The following is a description of a gene set: The process whose specific outcome is the progression of the central nervous system over time, from its formation to the mature structure. The central nervous system is the core nervous system that serves an integrating and coordinating function. In vertebrates it consists of the brain and spinal cord. In those invertebrates with a central nervous system it typically consists of a brain, cerebral ganglia and a nerve cord. species: Mus musculus Mouse Gene Set: GOBP_CENTRAL_NERVOUS_SYSTEM_DEVELOPMENT, and this is the list of marker genes: Slc4a7, Cldn3, Rnf7, Cckar, Tbc1d23, Lpar1 (lysophosphatidic acid receptor 1), Fmr1, Uqcrq, Ints15, Sema5a, Wdr62, Gfap, Grid2, Meis3 (NCBI Gene Id 17537), Ptf1a, Cxcl12, Aatk, Olig2, Arhgap32, Thoc6, Fezf1 (NCBI Gene Id 73191), Sez6, Cdh2, Mtf1, Mios, Pex5, Fgfr3, Hprt1, Top2b, Apod (NCBI Gene Id 11815), Ndel1, Cdon, Ryk, Faim2, Grn, Tgfb1, Opalin, Ckap5, Hap1, Fgf10, Mir124a-2, Fut1, Bbs2, Sox6, Agbl4, Wdr47, Ntrk2, Sox3, Reck, Kndc1, Rtn2, Tppp, Norad, Ttc21b, Dll1, Zbtb18 (zinc finger and BTB domain containing 18), Epha4, Bcl6, Hspg2, mt-Nd4, Nf1, Brsk1, Arl13b, Ugp2, Comt, S100a9, Shh, Sall3, Ttc8, Slc1a2, Qars1, Cdk5r2, Mtpn, Nrcam, Gabrb3, Spag6l, Pax4, Aspa, Vps4b, Hmx3, C2cd3, Crtac1, Fat3, Sphk1, Tubb2b, Drd1 (dopamine receptor D1), Slc6a17, Zswim6, Kcna2, Nr2c2, Lep (NCBI Gene Id 16846), Tlr2, Glud1, Runx1, Foxn4, Celsr2, Dmrt3, Ssbp3, Gak, Aldh3a2, Nsun5, Abl1, Nrros, Flvcr2, B3gnt5, Srd5a2, Rab23, Nfasc, Eef1ece2, Irs2, B2m, Atf2, Gsx2, Rac1, Dclk2, Sct, Plxna4, Enpp2, Ptprz1 (NCBI Gene Id 433999), Rbbp4, Noto, Gpx4, Fa2h, Met, Eed, Dubr, Id4, Pcm1, Dock7, Slc8a3, Pfdn1, Spg11, Csnk2a1, Vim, Ldb1, Bloc1s6, Atp2b4, Actl6a, Slc6a3, Zmiz1, Mafb, Kif14, Cers1 (ceramide synthase 1), Vcan, Hes5, Ifng, mt-Co1, Cx3cr1, Sox9, Gbx2, Bmpr1b (bone morphogenetic protein receptor, type 1B), Mecp2, Rhoa, Pou3f3, Brsk2 (NCBI Gene Id 75770), Anapc7, Zic2, Scn1b (NCBI Gene Id 20266), Pax7, Nav2, Skor2, Zfp488, Celf1, Dbi, Atp1a3, Cntn1, Dhx30, Nkx2-6, Wasf3, Cited1, Dag1, Efna1, Lrp6, Tuba1a, C1qa (NCBI Gene Id 12259), Hnrnpk, Fbxo45, Hnrnpd, Fez1, Klhl1, Gstp1, Rogdi, Rtn4, Mapk8ip3, Draxin, Sez6l, Mecom, Gcm1, Dnaaf3, Glis2, Kdm7a, Whrn (whirlin), Dll4, Ercc2, Foxc1, Agt (NCBI Gene Id 11606), Csnk1d (casein kinase 1, delta), Dab1, Map2k1, Mir376a, Svbp, Vps13b, Trpv1, Lypd6, Taok1, Hesx1, Btbd3, Ptprj, Macroh2a2, Dscaml1, Fxr1, Prkdc, Brinp1, Ptk2, Zeb1, Sox5 (SRY (sex determining region Y)-box 5), Bsx, Myo16, Prkg1, Rab18, Fyn, Lhx1os, Lhx2, Hdac11, Hoxa1, Epha2, Fgfr2, Rpgrip1l, Hif1a, Dicer1, Sstr3, Casz1, Atp2b2, Fktn, Zhx2, Psen2, Bpgm, Ngfr, Tbx20, Mir124a-1, Kif1a, Crkl, Scrib, Epha7, Vit, Smarcc2, Mapk3, Xrn2, Trem2, Wnt1, Casp3, Ttpa, Pbx3, Ntf3 (neurotrophin 3), Sox10, Napa, H2aj, Tacc1, Frs2, Rere, Atg16l1, Rrm1, Tyrobp, Grhl2, Nr3c1, Meis1, Hdac2, Gpr17, Rheb, Efhc1, Pantr2, Sema6b, Dcc, Stxbp3, Smarca4, En1, Bcan, Inhbb, Pgap1, Ncor1, Wls, Kirrel3, Ghrhr, Cxcr2, Emx2, Th, Plpp3, Psap, Ecrg4, Slc7a11, Tubb2a, Mdk, Gata2, Egfr, Tnfrsf1b, Pex13, Zic5, Sptbn4, Atrx, Foxo3 (forkhead box O3), Cep120, Cdk5r1, Cfap43, Nrp2, Ndp, Cplane1 (ciliogenesis and planar polarity effector 1), Stat3, Gap43, Atp6ap2, Socs7, Neurog2, Gba1 (NCBI Gene Id 14466), Crh, Tacc3, Uchl5, Sirt2, Mapk1, Dbx1, Sox13, Stil, Mag, Abcb1b, Smg9, Kcna1, Pitx2, Ldlr, Itgb1, Nfix, Mib1, Ighmbp2, Mir9-2 (NCBI Gene Id 723967), Adarb1, Atm, Mas1, Exoc4, Amigo2, Spef2, Mettl14, Plcb1, Atoh1, Immp2l (IMP2 inner mitochondrial membrane peptidase-like (S. cerevisiae)), Ntrk3, Drp2, Erbb2, Hoxb3, Bbs1, Ext1, B3glct, Sox21, Wdr1, Stk4, Cul5, Ptn, Arhgap35, Gsk3b, Zeb2, Cdk5, Atp1b2, Prkca, Med12, Lhx8, Psen1 (NCBI Gene Id 19164), Lsr, Kras, Fzd3, Phox2a, Pou4f1, Acan, Fgf2, Cacna1a, Zfp335, Mtor, Neurog3, Aplp2, Mir20a, Abat, Psmg1, Matcap1, Cln8, Kcnq2, Hsd17b7, Pomt2, Enpp1, Gmppa, Cbs, Git1, Ulk1, Gsn, Aars1, Trp73, Tctn1, Gbx1, Hoxb8, Dkk1, Cntn4, Slc6a4, Trp53, Plxnb2, Drd3, Dlx2, Pou4f2, Fxr2, Coro1c, Dhx37, Sun1, Mir18, Kcne1, Vax1, Gdpd5, Scyl3, Mir200c, Tpp1, Pitx1, Akna, Avpr1a, Sstr1, Mir200b, C5ar1, Dner, Nr1d1, Rtn4r, Pou3f4, Ophn1, Pkd2, Il6st, Aim2, Gli3, S100a8, Mkks, Sphk2, Kif3a, Gdnf, Foxp1, Six3, Dctn1, Anxa3, Rtn4rl2, Tbx3, Foxg1, Shroom4, Pafah1b1, Robo2, Dmd, Jhy, S1pr1, Fzd4, Atp7a, Bmp4, Slc2a1, Pbx4, Odad2, Zpr1, Nrxn1, Mir219a-1, Foxb1 (forkhead box B1), Neurod4, Tgfbr2, Macrod2, Wnt5a, Cend1, Rtn4rl1, Spock1, Kif26a, Lamb2, Pitx3, Grcc10, Prop1, Ifngr1, Pygo2, Ttn, Fat4 (NCBI Gene Id 329628), Otx1, Ager, Duox2, Sox15, Ccdc134, Ctns, Llgl1, Fabp7, Htr5a, Clcf1, Ndst1, Nanos1, Sin3a, Slc32a1, Mettl3, Prmt5, Creb1, Chd7, Septin4, Slit1, Shroom2, Lmx1b, Brca2, Mir17, Suz12, Sec24b, H2ax, Trnp1, Scin (NCBI Gene Id 20259), Pomgnt1 (NCBI Gene Id 76888), Mpst, Atxn2, Alk, Kif21b, Sun2, Pax2, Oxtr, Hspa8, Myh10, Hes3, Hoxd10, Magee2 (MAGE family member E2), Kif27, Tgif1, Eif2b2, Htra2, Prdm13, Ncan, Ubb, Src (NCBI Gene Id 99351), Slitrk5, Uba6, Cdk20, Prpf19, Ror2, Lrp1, Gabrb1 (gamma-aminobutyric acid type A receptor subunit beta 1), Lonrf2, Plxna1, Ankle2, Secisbp2, Dmrta2, Il1b, Hoxb2, Slc1a1, Esr2, Mir429, Lhx3, Ttbk2, Mcph1, Bglap2, Cluap1, Large1, Ppt1, Mfsd8, Chd8, Twsg1, Tfap2d, Amigo1, Pkd1, Btg2, Rarb, Tmx2 (NCBI Gene Id 66958), Lmx1a, Rbpj, Nf2 (NCBI Gene Id 18016), Syne2, Egr2, Ndufs4, Nefl (neurofilament, light polypeptide), Cox7b, Dscam, Pbx2, Unc5d, Akirin2, Foxr1, Dlc1, Dixdc1, Gpm6b, Lef1, Arhgef28, Gnpat, Dct, Plxna3, Elavl4, Chrnb2, Gba2, Apaf1, Odad4 (NCBI Gene Id 74407), Epha5, Dlx1, Odad3, Gas1, Mycbp2, Zic4, Bmp7, Otx2, Nlgn3, Cdkn2c, Smarca1, Srgap2, Mir23a, Lrp5, Dync2h1, Vsx2, Mdga1, Tlx1, Wnt9b, Setd2, Mir200a, Adgrg1, Vps54, Lyn, Cntf, Foxp2, Ttc36, Pbx1 (NCBI Gene Id 98516), Nr2f1, Afdn, Tspan2, Tbx19, Bag3, Sox4, Itgam, Mfsd2a, Npy, Adora2a, Clp1, Lhx4, Neurog1, Ptprs, Ghrh, Marcks, Adgra2, Hoxb1, 9630013A20Rik, Mir9-3, Sema4c, Ascl1, Tra2b, Disc1, Nes, Akt1, Mxra8, Aldh1a3, Rax, B4galt6, Egf, Eif2b5, Gdf10, Stk36, Nars1, Meis2, Bin1, Hook3, Lrrk2, Id2, Hoxc10, Fbxo41, Rbfox2, Kdm4b, Kdm4a, Lamb1, Kdm2b, Slit2, Elp3, Fancd2, Kdm6b, Map1s, Miat, Phactr1, Vstm5, Tubgcp2, Zdhhc16, Nrg1, Pou1f1, Kcna3, E2f1, Pcdh18, C3, Isl2, Sema6d, Igf2bp1, Hapln4, Epor, Olig3, Slc23a1, Zic3, Tal2, Nfe2l1, Eif2b1, Six1, Bmpr1a, Bhlhe22 (basic helix-loop-helix family, member e22), Bcl11b, Szt2, Rara, Nrg3, Nlgn4l (NCBI Gene Id 100134948), L1cam, Fcgr2b, Aspm, Bmerb1, Mrtfa, Ncoa6, Xrcc1, Barhl2, Cyp26b1, Dusp10, Sema3e, Ephb2, Filip1, Tacc2, Numb, Kdm1a, Slc38a2, Utp3, Lig4, Inhba, Col4a1, Med1, Vps51, Ctnnb1, Cul4b, Bnip3, Ephb3, Pax8, Unc5c, Rbbp7 (NCBI Gene Id 245688), Sall1, Col2a1, Rtn1, Trappc9, Nkx2-1, Tcf7l2, Agtr2, Nr4a2, Nog, Sema7a, D16Ertd472e, Hmga2, Tnfrsf21, Mast1, Wdr37, Abca2, Ufc1, Tbx1, Lrp2, Ttll1, Gdf7, Ncor2, Ift88, Sfrp1, Sema3a, Vps13a, Dusp15, Mbd1, Setd1a, Loxl3, Eml1, Cln5, Fuz, Mobp (myelin-associated oligodendrocytic basic protein), Smad9, Bok, Sox14, Mnx1, Kcnc1, Aqp1, Pax3, Sox8, Apbb1, Hapln1, Mboat7, Nnat, Aldh1a2, Bbs7, Dlg5, Hnf1b, Lhx6, Gsx1, Mir19a, Mal (NCBI Gene Id 17153), Ngf (nerve growth factor), Nkx2-2os, Plp1, Hydin, Coq8b, Kat2a, Pdss2, Atf5, Nme5, Selenop, Slc45a3, Nr2e1, Sfrp2, Bag6, Sema3f, Mme, Cwh43, D130043K22Rik, Atxn1l, Sptbn2, Wnt2, Dnah5, Mir9-1, Lrp8, Scn2a, Nodal, Crk, Gli2, Xrcc4, Ufm1, Ptchd1, Erbb4, Grk2, Afg2a, Gli1, Flna, Wdr89, Sox1, Ndn, Marcksl1, Notch3, Actr3, Stk3, Fgf8, Lhx1, Hapln2, Prox1, Gdf11, Dmbx1, Barhl1, Agtpbp1, Tlr4, Smad1, Grhl3, Usp9x, Mir19b-1, Abcb1a, Ncstn, Mgarp, Rac3 (NCBI Gene Id 170758), Abr, Cited2, Tox, Eomes, Cyp26c1, Tsc1, Hapln3, Rorb, Slc4a10, Foxa2, Nme7, Mycn, Grin1, Sox2, Gas8, Mnat1, Drgx, Gart, Tfap2c, Lhx5, Tenm4, P2ry12, Lif, Il33, Numbl, Rtn3, Scyl2, Pparg, Sptbn1, Aplp1, Nr4a3, Sox11, Maco1, B4galt2, Cntnap2, Arl6, Gnaq, Bbs4, Isl1, Pou3f1, Csk, Nr2f2, Abcc1, Dab2ip, Phox2b, Mir92-1, Vldlr, Vtn, Wnt3a, Fezf2, Bcl2, Ackr3, Robo1, Neurod1, Otp, Atg7, Prdm8, Ror1, Smo, Tnr, Fut10, Wnt7a, Abl2, Msx1, Phf8, Ppp1r9b, Ier3ip1, Ddit4, Cic, Slc25a46, Fos, Il34, Dpcd, Pianp, Sdf4, Ptch1, Igf1, Axl, Nfib, Wnt7b, Hhex, Cdk5rap2, Bax (NCBI Gene Id 12028), Efna2, Kcnj10, Upf3b, Tbr1, Capg, Cdh11, Cnp, Nde1, Nkx2-2, App, Nkx6-2, Dll3, Dvl3, Naglu, Ak8, Abt1, Csf1r, Ndnf, Git2, Avpr2, Pak1, Nipbl, Ptger3, Diaph1, Neurod6, Rfx4, Aldh5a1, Ncam1, Htt, Id3, Fgfr1, Atp1a2, Chd5, Lingo1, Ski, Atrn, Ogdh, Foxj1 (NCBI Gene Id 15223), Pals1, Lbx1, Lmo4, Gabra4, Amigo3, Htr6, Msi1, Ift172, Intu, B4galt5, Ptpra, Dlx5, Arx, Adcyap1, Arcn1, Tyro3, Olig1 (oligodendrocyte transcription factor 1), Tmem108, Cd3e, Sstr2, Clu, Sos1, Mink1, Wnt3, Dclk1, Ywhae, Neurod2, Trp53bp2, Clcn2, Zfp365, Vax2, Ccdc85c, En2, Dnajc30, Nrp1, Srf, Cbln1, Dcx, Tmem98, Evx1, Anp32b, Nin, Zic1, Zc4h2, Hdac1, Kifbp, Shank3, Kcnc2, Hspa5, Wnt4, Bcr, Ikzf1, Rora, Pias4, Pten, Notch1, Mir141, Nova2, Arid1a, Cep290, Daam2, Eif2b4, Myd88 (NCBI Gene Id 17874), Tgif2, Atxn1 (NCBI Gene Id 97894), Scyl1, Fzd6, Pomk, Mir124a-3, Brinp3 (bone morphogenetic protein/retinoic acid inducible neural specific 3), Pcsk1, Qki, Hoxa2, Cxcr4, Cntn2, Trpc4 (transient receptor potential cation channel, subfamily C, member 4), Dmxl2, Ccdc141, Gpr37l1, Tlx3, Msi2, Ccdc39, Tal1, Negr1, Serpine2, Ptpn11, Gria1, Chrd (NCBI Gene Id 12667), Plxdc1, Bptf, Drd2, Fgf13 (fibroblast growth factor 13), F2, Cntnap1, Ak7, Hes1, Gm5849, Atat1, Igf1r, Arnt2, Phgdh, Gigyf2, Ang, Fancc, Ezh2, Foxp3, Myrf, Sez6l2, Tsku, Tulp3, Ncoa1, Pax5, Eif2b3, Bmi1, Atic, Col3a1, Ulk4, Gsc (NCBI Gene Id 14836), Ift80, Sox12, Ctnna2, Wnt2b, Herc1, Akt3, Pax6, Omg, Tfap2a, Helt, Ift122, Samd4b, Emx1 (NCBI Gene Id 13796), Sufu, Plxna2, Reln, Cyp26a1, Gpr158, Nhlh2, Pou3f2, Bglap, Hmx2, Rapgef2, Mir219a-2, Ephb1, Abcb6, Pcnt, Lamc3, Rab3gap1, Fkrp, Uncx, Bmp5, Mrtfb, Bmp2, Fbxw11, Nkx6-1, Zfp423, Brinp2, Sec1